Given this list of marker genes FBXO2, GET4, UBQLN2, RHBDD1, MARCHF6, NCCRP1, UBXN2A, NPLOC4, JKAMP, TMEM259, TRIM25, AFG2B, TRIM13, ATXN3, SEL1L, PSMC6, VCP, FAF1 (Fas associated factor 1), FOXRED2, DNAJB2, MAN1A2, HSP90B1, UBXN8, BRSK2, MAN1B1, DNAJB12, UBXN1, EDEM3, TOR1A, CALR, XBP1, FBXO27, TMEM67, CAV1, ECPAS, DERL3, RNFT2, CANX, DNAJB9, PRKN, STT3B, AMFR, RNF185, UBQLN1, SYVN1, BCAP31, RCN3, USP13, RNF175, HM13, USP19, TMEM129, AUP1, RNF5, RHBDD2 (rhomboid domain containing 2), SGTA, ERLIN1, ATXN3L, RNF139, ERLIN2, DERL1, EDEM2 (ER degradation enhancing alpha-mannosidase like protein 2), UBE2J2, FBXO44, CCDC47, SEC61B, OS9, ANKZF1, UBAC2, YOD1, UFD1, USP25, FBXO6, MAN1C1, HERPUD1, ERLEC1, RNFT1, CLGN, MAN1A1, NFE2L2, UBXN4, UBXN6, SELENOS, RNF145, UBE4B, UBE2G2, BAG6, UBE2J1, FAM8A1, SVIP, CALR3, SEL1L2, USP14, SDF2L1, FAF2, AQP11, FBXO17, DNAJC10, ATF6, EDEM1, DERL2, STUB1, TMUB2, RNF103, UBE4A, UMOD, WFS1, TMX1, UBXN10, TMUB1, HSPA5, RNF121, here is a description of the gene set: studied in species Homo sapiens The protein catabolic pathway which targets endoplasmic reticulum (ER)-resident proteins for degradation by the cytoplasmic proteasome. It begins with recognition of the ER-resident protein, includes retrotranslocation (dislocation) of the protein from the ER to the cytosol, protein modifications necessary for correct substrate transfer (e.g. ubiquitination), transport of the protein to the proteasome, and ends with degradation of the protein by the cytoplasmic proteasome. Human Gene Set: GOBP_ERAD_PATHWAY